Given this list of marker genes APOA1, APOB, APOC4, APOC1, ABCA1, APOA2, PRKACB, PRKACA, SAR1B, MTTP, P4HB, PRKACG, APOC2, APOE, ZDHHC8, APOC3, APOA4 (apolipoprotein A4), A2M, BMP1, here is a description of the gene set: Plasma lipoprotein assembly Human Gene Set: REACTOME_PLASMA_LIPOPROTEIN_ASSEMBLY species: Homo sapiens